The following is a description of a gene set: Diaphyseal undertubulation Tubulation refers to the size and shape of tubular bones. In children and adolescents, the modeling process regulates normal bone growth. Final shaft (tube) diameter depends on appositional bone growth and the equilibrium between periosteal and endosteal bone resorption and formation. Undertubulation refers to a broad, widened form of the shafts (diaphyses) of long bones. Human Gene Set: HP_DIAPHYSEAL_UNDERTUBULATION species: Homo sapiens, and this is the list of marker genes: LRP4, IDUA, PTDSS1, ERI1, PPIB, SOST, SLC35D1, LBR (NCBI Gene Id 653311), IDS, LRP5 (NCBI Gene Id 8058), GUSB, RMRP (NCBI Gene Id 6023), LIFR, TBXAS1, SHOX, SP7, INPPL1